Given this list of marker genes MCM2, LINC00839, TMEM200A, SGF29, RNF121, LINC00865, HJURP, RITA1, TMEM106C, CLDN1, CENPA, ADAT3, BIRC5, TREML1, CD151 (CD151 molecule (Raph blood group), NCBI Gene Id 977), EPHA1, COQ3, SNTG2-AS1, TBC1D27P, HMGB3, TSPAN33, AQP3, ST6GALNAC1, LINC01618, SPAG5, CMTM5, ENO2, MCC, NEIL3, CDKN3, FEN1, SKP1, ST7-AS1, GP1BA, HOXB1, CAV1, HSD3B7, ZNF678, CCNE1, SOSTDC1, FMO9P, LRRTM4, YY2, DSG4, NEK2, ESCO2, DYNC2I2, SPHK1, FAM83D, LBX2-AS1, PRDM1 (NCBI Gene Id 639), IGSF9B, C22orf23, PLEKHG4, GUCY1A1, KIF4A, HIVEP3, SPOCD1, KISS1R, PIK3R3, CDCA4, ACAT2, BEX3, ADGB, CTSG, BUB1B, HSPA2, USP53, WWOX, TROAP, TSGA10, KIF18B, LINC01692, KLHDC8B, FIRRM, CRTC1, LIPC, RAB39A, HEPACAM (hepatic and glial cell adhesion molecule), CENPN, CLDN14, BYSL, SNX25, CPA3 (carboxypeptidase A3), MBNL1-AS1, CKAP2L, ITGB3, IL36B, FAM50B (NCBI Gene Id 26240), SELP, GPR19, SYTL4, NRGN, ZSCAN12P1, SSX2IP, OR4D2, EYA3, PCLAF, DDX51, PRTN3, RRS1-DT, CMTM8, SIRPG, GNAZ, IL2RA, CFH, PF4, CSTF3-DT, OIP5 (NCBI Gene Id 123752), CFAP184, DIAPH3, PRTFDC1, LTBP1, DLGAP5, CIT, PACRG-AS1, GLDC, UBE2T, MKI67, RPL39L, PSAT1, SUCNR1, KIF2C, AURKA, MARCHF2, TCEAL9, DEPDC1B, RAD51, EMC9, POLQ (DNA polymerase theta), NBR2, CDCA5, CCNB2, GALNT12, NANOS1, LIME1, ATP8B5P, F3, ASF1B, MLPH, CEP55, AIFM2, LINC00870, PTTG1, CNN1, RAD54L, MPV17L2 (NCBI Gene Id 84769), CATSPERZ, MEIG1, PCYT2, CHAC1, ISG15, PRRG3, IFI27L1, MGLL, KIF20A, H4C3, ZMYND12, MTFR2 (mitochondrial fission regulator 2), ESPL1, INF2, DENND5B, SLC25A4 (NCBI Gene Id 7872), MCM10, TRIP13, FOXR2, CDCA3, DAD1, SERPINI1, SEMA4C, PLOD2, PLK1, COX6A1, TMEM158, LGMN, ATP1B1, BHLHE41, ACRBP, TRBV7-3, TSSK2, DPY19L1P1, PHKA1, ENSG00000237250, ITGA2B, TCF19, GRIN3A (NCBI Gene Id 138370), GPR15, ERCC6L, SLC6A4, PPBP, FBXO10, MAD2L1, NUF2, here is a description of the gene set: Genes down-regulated in CD8 T cells: control versus primary acute viral infection. Human Gene Set: GSE45365_WT_VS_IFNAR_KO_BCELL_MCMV_INFECTION_DN Murine Cytomegalovirus (MCMV) infection leads to early activation of various immune cells, including B and T lymphocytes, before the actual initiation of antigen-specific adaptive immunity. This activation is partly driven by innate cytokines, including type I interferon (IFN), which are induced early after infection. The objective of this study was to address the role of type I IFN in shaping early/innate B and T cell responses to a primary acute viral infection. In order to decipher the specific impact of IFN-I on cell subsets, we performed a genome-wide expression analysis on WT splenic B and CD8 T lymphocytes isolated from C57BL/6 mixed bone marrow chimera mice. This study complements series GSE39555, which focused on early responses of NK cells and of the two subsets of conventional dendritic cells. species: Homo sapiens